Given this list of marker genes KRTAP11-1, LTB4R, DYTN, FCAMR, TWF2, FBXO27, MAP3K2, TPO, MIR148B, PABPC1, BTBD6, SNRPD3, ICOS, ADGRL3, PLA2G4A, FMO5, NTMT2, FNBP1L, SHISA5, IWS1, SLC35G2, AMH (anti-Mullerian hormone), KDSR, POMGNT2 (protein O-linked mannose N-acetylglucosaminyltransferase 2 (beta 1,4-)), ETV3, IGDCC3, USP26, VPS13A, NINL, NAT8, UBA6, APBB2, CFAP45, STAP1, SLC25A41, NAV1, ADGRA2, RPL37A, SGSM1, CEP70, CACNG2, WBP2NL, FMOD, CD160, PKLR (pyruvate kinase L/R), MRAS, LTK, RYR3, EIF3E, MARCHF10, PIAS2, CELF3, PWWP2A, ABCG5, TTC16, ICAM5, LYZL4, SPDYE4, AVL9, MIA, CCBE1, TJP3, TSPAN1, SSX9P, TTC5, ADAMTS15, RCC2, DKK2, VASH2, CCND1, UVRAG, TMEM44, MMP20, PATL1, MAP4K4, F2RL3, PRKAB2, ADAMTS14, THOC2, KCNK4, DKC1, KLHL24, AGO2, TCL1A, KALRN, GYPC, ZBTB24, TIMD4 (T cell immunoglobulin and mucin domain containing 4), CCL3, SELE, KCNJ6, APBB1IP, PLPP2, HOXC12, SETBP1, FOXI2, DEPDC5, RPS4Y2, KLF17, TMEM41A, SLC23A2, FNTB, VTN, PHF14, TTLL13, CPNE7, WNT7A, CCDC158, FAM216B, CADM2, CBARP, TLK2, TRIM52, GPR37L1, SYNPO2, DLEU7, LAMP3, KDM4B, TPM3, SAA2, DNAJC17, DLX6, ELL3, WFDC2, ANKRD9, BYSL, MICAL3, CAPN15, LPO, LTBP4, GALNT15, PRELID3A, SHD, VSX2, IL31, CHD2, HCAR1, PCF11, RAB39A, TRMT112, MPP2, TRIM71, here is a description of the gene set: IL-10 or IL-6 stimulation of control 129xC57BL/6 murine bone marrow derived macrophages in the presence of LPS. We used microarrays to detail the global programme of gene expression changes in response to IL-6 or IL-10 stimulation in the presence of lipopolysaccharide. BMDMs were isolated from control, IL-6-/-, and IL-10-/- mice on a 129XBL/6 mixed background mice and differentiated in the presence of CSF-1 for 6-7 days. Cells were scraped and plated in 6 well plates at 2x10e6/well. Cells were washed with complete DMEM and rested for 1-2 hr before stimulation with combinations of IL-10 (10 ng/ml), IL-6 (2 ng/ml) or LPS (100 ng/ml) for 45 min or 180 mins. Complete biological replicates were performed. studied in species Homo sapiens Human Gene Set: GSE5589_WT_VS_IL6_KO_LPS_STIM_MACROPHAGE_180MIN_DN from publication El Kasmi KC, Holst J, Coffre M, Mielke L, de Pauw A, Lhocine N, Smith AM, Rutschman R, Kaushal D, Shen Y, Suda T, Donnelly RP, Myers MG Jr, Alexander W, Vignali DA, Watowich SS, Ernst M, Hilton DJ, Murray PJ (PMID 17114459) Genes down-regulated in bone marrow-derived macrophages at 180 min of stimulation byLPS: wildtype versus IL6 knockout.